Given this list of marker genes CKAP5, WAPL, CLASP1 (NCBI Gene Id 23332), PPP2R5D, CENPT, SEC13, CLIP1, PPP2R5E, CENPH, SPDL1, CENPM, KIF2C, CENPU, CENPK, TUBA1C, TUBA1A, TUBB1, MIS12, SMC1A, AHCTF1, MAD1L1, ZW10, TUBB8, NUP43, ZWILCH, TUBA3D, CENPI, ERCC6L, TUBA8, TUBA3E, CENPC, CENPL, SGO2, BIRC5, PLK1, RANGAP1, CCNB1, RANBP2, CENPS, KNL1, AURKB, TUBB2B, KIF18A, NUP160, PDS5B, RPS27, FIRRM, CENPO, PPP2R5C, CENPA, RCC2, INCENP, DYNC1I1, PPP2R5A, CDC20 (NCBI Gene Id 991), NUP85, PPP2R1B, TUBB6, TUBA1B, MAPRE1 (microtubule associated protein RP/EB family member 1), RAD21, PDS5A, PMF1 (polyamine modulated factor 1), HDAC8, MAD2L1 (NCBI Gene Id 4085), TUBB3, TAOK1, DYNC1H1, TUBAL3, DYNLL1, NDEL1, TUBB2A, CENPQ, DYNLL2, SKA1, STAG2, TUBA4A, DYNC1LI2, TUBA3C, ITGB3BP, PPP2R1A, TUBB8B, CENPP, SKA2, KIF2B, NUP98, NUDC, PPP2CA, NDC80, PAFAH1B1, NSL1, SMC3, CENPF, BUB1B, TUBA4B, CENPE, BUB3, SEH1L, TUBB4B, CENPN, CLASP2 (cytoplasmic linker associated protein 2), BUB1, CCNB2, DYNC1I2, DSN1, PPP1CC, PPP2CB, XPO1, DYNC1LI1, ZWINT, STAG1, NUF2, TUBB4A, CDCA8, SGO1, SPC25, PPP2R5B (protein phosphatase 2 regulatory subunit B'beta), CDK1, NDE1, NUP133, SPC24, B9D2, KNTC1, NUP37, CDCA5, KIF2A, NUP107, here is a description of the gene set: studied in species Homo sapiens Human Gene Set: REACTOME_RESOLUTION_OF_SISTER_CHROMATID_COHESION Resolution of Sister Chromatid Cohesion